The following is a description of a gene set: The orderly movement of a cell from one site to another that will contribute to the progression of the kidney over time, from its formation to the mature organ. Human Gene Set: GOBP_CELL_MIGRATION_INVOLVED_IN_KIDNEY_DEVELOPMENT studied in species Homo sapiens, and this is the list of marker genes: VANGL2, ADIPOQ, GDF6, PDGFRB, PDGFA, PDGFB